The following is a description of a gene set: PI-3K cascade:FGFR3 species: Mus musculus Mouse Gene Set: REACTOME_PI_3K_CASCADE_FGFR3, and this is the list of marker genes: Pik3r1, Fgf16, Grb2, Fgf2, Fgf9, Fgfr3, Fgf8, Gab1, Frs2, Fgf23, Fgf4, Pik3ca, Fgf20, Fgf1, Fgf18, Ptpn11 (NCBI Gene Id 72646), Fgf5, Fgf17